Given this list of marker genes CCNB1, PPP2R2D, PPP2CB, CDK1, PPP2R1A, ARPP19 (NCBI Gene Id 10776), PPP2CA, MASTL, PPP2R1B, ENSA, here is a description of the gene set: studied in species Homo sapiens MASTL Facilitates Mitotic Progression Human Gene Set: REACTOME_MASTL_FACILITATES_MITOTIC_PROGRESSION